Given this list of marker genes HBEGF, NRG1, ERBB2, EREG, ERBB4, here is a description of the gene set: The series of molecular signals initiated by binding of a ligand to a ERBB4 receptor on the surface of a cell, followed by transmission of the signal by a heterodimeric complex of ERBB2 and ERBB4. ERBB2, which does not bind any known ligand, is activated through formation of a heterodimer with another ligand-activated ERBB family member such as ERBB4. studied in species Homo sapiens Human Gene Set: GOBP_ERBB2_ERBB4_SIGNALING_PATHWAY